The following is a description of a gene set: Underdevelopment (reduced size) of the tibia. Short tibia species: Homo sapiens Human Gene Set: HP_SHORT_TIBIA, and this is the list of marker genes: LMBR1, SLC35A2, CEP120, SMOC1, RTL1, BMPR1B, SHOX, LIFR, SHH, GPC6, TCTN3, FLNB, NEK1, IHH, SLC31A1, ALG12, LAMA5, MEG3, GDF5, GLI3, HYLS1 (NCBI Gene Id 50957), ZSWIM6, INTU, DONSON (DNA replication fork stabilization factor DONSON), DLK1, EIF4A3